The following is a description of a gene set: The attachment of one cell to another cell via adhesion molecules. species: Homo sapiens Human Gene Set: GOBP_CELL_CELL_ADHESION, and this is the list of marker genes: MIR141, CD58, BMI1, LGALS1, TLN2, JUP, FXYD5, SPI1, ESAM, ZFP36L1, NCAM2, SDK1, BOC, YES1, ELANE, METAP1 (methionyl aminopeptidase 1), FNDC3A, LRRC4, DAPL1, EPCAM, HES1, HBB, PCDHA6, CCL19, STXBP3, CEACAM6, CDH8, PODXL, SMARCD2, NFKBIZ, CELSR2, CBLB, CITED2, SPINT2, GLI2, VTCN1, ATP1B2, FUT7, ITCH, MIA3, CD84, IL2RA, NCK1 (NCBI Gene Id 4690), ANK3, CYFIP2, HLA-DPA1, CBFB, MIR221, GOLPH3, NFASC, CELA2A, ITGA2B, DLG5 (discs large MAGUK scaffold protein 5), IL12B, MMP24, PRKAA1, KIF26B (kinesin family member 26B), PTPN2, BMP7, PPP3CA, MYPN, BAIAP2, COL19A1, RAP2B, NLGN1, CADM2, EFNA5, CALCA (NCBI Gene Id 87044), PCDHGA1, CLSTN2, RGCC, HLA-DQA1, ITGB8, PCDHGC3, BHLHA15, PCDH8, DHPS, ITPKB, PTPRG, GP6, FGG, IGDCC3, ABL1, AKT1, FGFRL1, PCDHGB3, PLEKHA7, CDH7, NFKBID, DSCAML1, BSG, ANXA2, ARG2, ZBTB7B, IL1RAP, CYRIB, PTK7, PCDHGA9, MAP2K1, LAMA3, AMBRA1, TNFSF14 (TNF superfamily member 14), PCDHGC4, BTNL2, THY1, CD55, JAK3, ITGAV, HLA-DQB1, NTN1 (NCBI Gene Id 9423), TSPAN9, BAD, CCL5, PRKCQ, MIR125A, CD200, ZBTB16, SERPINF2, PCDH19, EPB41L5, PCDHA8 (protocadherin alpha 8), CLDN8, LRRC4C, CTNNA3, GCNT2, PRNP, TNXB, NLGN4Y, SELP (NCBI Gene Id 6403), CLDN2, SRPX2, TRIM29, NOD2, SCARF2, LRFN3, HLA-DRB5, LEF1, CX3CL1, PCDHB4, STAT5A, CDH1, SLC39A8, PVR, ATP2C1, PCDHB3, DSC3, JAK2, ITGA5, KRT18, CD2AP, CDON, MYL12A, MMRN1, CBLN1, NEXMIF, TUBB1, PCDHA9, CDH23, PCDHB12, EMB (embigin), SOCS5, PCDHB7, IL12A (interleukin 12A), ASCL2, PCDHA12, TNFRSF21, S100A9, TIGIT, FAT4, IL1A, CD6, FOXA2, FUT4, CXADR, ADGRG1, ITGA10, ADD2, CTNND1, SDC4, ARVCF, NTNG1, FUT9, CD80, FLOT1, NCK2, PCDHA13, TYRO3, LGALS8, SMARCD1, DLG2, LGALS3, CTSG, IGSF9, PIK3CG, SLITRK3, DUSP10, TNFRSF14, CCL21, TYK2, GNRH1, IGSF11, PTK2, CHST4, BCL2, SDK2, CD40LG, MTOR, KAT5, ADGRV1, DCC, CDH16, EGR3, NDFIP1, SOX12, CLDN18, AP3B1, HLA-DRB4 (NCBI Gene Id 3126), IGFBP2, BRD7, BMP4, TRAF6, AJUBA, AMIGO1, PCDHGA2, CXCL12, PSEN1, SOX4, RHOH, CDH20, SOCS1, TNFSF4, CARD11, IZUMO1, TMOD3 (tropomodulin 3), NKAP, SCARF1, IGDCC4, PCDHGA11, ELFN1, CDH18, STXBP1, CD5, ICAM4, ITGB4, WNT1, ITGB5, IL10, CDH12, CEACAM8, TGFB1, NPHP1, PCDH20, S100A8, GATA1, SCRIB, ST3GAL4, RARA, ROCK1, IL1RN, LIMS1, CLDN4, FOXP3, GPC4, CNTN5, PYCARD, ITGB6, CSK (C-terminal Src kinase), XG, CD70, ROBO2, SLAMF1, SLC6A4, HLA-DPB1 (major histocompatibility complex, class II, DP beta 1), UMOD (NCBI Gene Id 7369), CLDN3, KIT, SLITRK5, HSPB1, BVES, CADM1, THBS4, ACVR1, PCDHGA3, CLDN5, FGL2, PTPRM, PPIA, S100A11 (S100 calcium binding protein A11), MYL9, PLA2G2A, CD99, PIP5K1C (NCBI Gene Id 23396), IL7, ITGA1, PCDH10, CDSN, PCDHGA8, CCR7, PRKAR1A, RC3H2, PCDHA5, XCL1 (X-C motif chemokine ligand 1), ITGA7, CTNNB1, VMP1, RHOA, GRID2 (glutamate ionotropic receptor delta type subunit 2), LEP, PCDH11Y, CDH4, UFL1, ROBO4, MEGF11, PSG5, ALOX5, LYN, GPR65, CDH17, MIR21, MIR30B, SLITRK2, TNFRSF13C (NCBI Gene Id 115650), NEGR1 (neuronal growth regulator 1), FIBP, IL1RAPL1, MADCAM1, CORO1A, COMP, TSPAN32, PRDX2, PLPP3, VSIR, PCDH11X, PPARA, VSIG10L2 (NCBI Gene Id 338667), GTPBP4, KIRREL1, CADM3, STAT5B, ANXA1, ITGAL, IRF1, PTPRF (protein tyrosine phosphatase receptor type F), PTPRU, TNF, SASH3, ARID2, CTNNA2, RC3H1, ALOX12, NRXN2, PCDHGB1, ITGB1, PELI1, PTPRC, RAG1, TMIGD1, CASP3 (caspase 3), CLEC4G, GATA5, CDK5R1, MBP, KIFC3, OPA1, LILRB4, LAPTM5, ACTB, NTNG2, CSRP1, KIRREL3, EFNB3, SHH, CNTN2, ZMIZ1, EGFR, RDX, PKP4, CDH3, CLDN16, CD24, LGALS2, NECTIN2, DUSP3, CDHR4, CEBPB, CDH5, DLG4, ADAM19, AKNA (AT-hook transcription factor), MAP3K8, PLXNB2, HLX, C1QTNF1, LAG3, STXBP6, CRTAM, METTL3, ARG1, CDHR5, SMARCC1, ITGA9, IL36B, PCDHA2, RIC8A, B2M, OLR1, MYH9, TJP2, VAV1, FLOT2, PRKCA, PLAUR, CD44, FSTL3, TGFB2, SMARCE1, DSC2, COL13A1, GLDN, CLDN17, CLDN11, CCDC88B, NR5A2, PNP, NF2, EMILIN2, FGB, CD9, ETS1, VNN1, MSN, ZP3, ILDR2, VSIG4, SPARCL1, FUT3, CDHR2, EPHB3, CDH22, PCDHGB4, MYOT, TNFSF9 (TNF superfamily member 9), HLA-A, SOX9, SLC7A1 (NCBI Gene Id 6541), GPAM, WNT5A, LOXL3, TBX21, SART1, SLC7A11, TNFSF11, KLHL25, ZDHHC21, CCL28, WNT7B, PARVA, SFN, LRP6, UBASH3B, SOX2, BMP5, CBLL1, SLITRK1, IL1B, MAPK14, SIGLEC1 (sialic acid binding Ig like lectin 1), DSG2, RUNX1, NEO1, COL14A1, MIRLET7E, F2RL3, CDH15, PCDHGA5, CELSR1, MIR92A1, PCDHB6, SELPLG, CLDN19, TNFSF18, NOTCH1, PLXNB3, CTNNA1, PRICKLE1, DAB1, HSPH1, FOXF1, PCDHGA12, MPZ, IFNL1, RASAL3, SELE, LRFN4, KLHL22, SWAP70, RELA, COL8A2, CD4, PDGFRA, PCDH9, IL4I1, CLDN15, ICAM1, CYLD, HLA-DRB1, CRNN, SIRPA, NR4A3, PCDHB18P, MDK, TRO, CD28, ITGAD, ICOSLG, APOA1, PDPN (NCBI Gene Id 29912), ASTN1, JAG1, CLDN20, ADIPOQ, LRRC32 (NCBI Gene Id 2615), MIR31, MAP2K5, EFNB1, KITLG, PSG2, GATA3, PCDHGA10, MAD1L1, NECTIN1, VEGFA, IL4, ZP4, CAMSAP3, PDCD1LG2, DLG1, HMGB1, ZAP70, EFNB2 (ephrin B2), FADD, AMIGO3, PCDHB10, ANXA9, DSG1, CRB1, CCN3, MPZL2, TARM1, CCL25, STK10, CD81, CEACAM5, RAB10, PDLIM5, ELFN2, CD86, PLA2G2D, PCDHA10 (NCBI Gene Id 56139), ZBTB1, CDH10, FAT1, MUC21, PRTG, PRKCZ, PHF10, BTLA, BMP2, DOCK8 (NCBI Gene Id 81704), ENTPD1, PCDHGA4, MYO10, LRRC4B, PTPRD (protein tyrosine phosphatase receptor type D), ROBO3, NINJ1, PAG1 (NCBI Gene Id 55824), CYP1B1, IRAK1, SRF, FLRT3, MIR146A, HAVCR2, CX3CR1, EZR, ICAM2, PCDHAC1, FAT2, YWHAG, CLDN7, ARID1B, ASS1, LILRB2, CDH19, PLA2G2F, DSP, CD274, JAM3, DTX1, ITGA4, HLA-DQA2, PCDHA3, MAD2L2, PKP2, CDH11, SMARCA2, CCR2, TMEM131L, ZC3H12A, WNT10B, LGALS9B, RAC2 (NCBI Gene Id 5880), FERMT3, PCDHB9, GFUS, CD33, CR1, DPP4, CD160, BMP6, DCHS1, PCDHB13, ICOS, ITGAX, MFSD2B, VCL, CD69, ABCA12, IL7R, IL6ST, LIMS2, PECAM1 (NCBI Gene Id 5175), KIFAP3, IGF2, IFNA2, KLF4, PCDHB16, ITGA3, TJP1, IL1RL2, CDH6, SIRPG, TLN1, NINJ2, CNTN4, ACTG1, MIRLET7G, HLA-DRB3, ITGB3, PCDHGA7, IL23A, DSG4, SFTPD, NPTN, FBXO38, RAP1GAP (RAP1 GTPase activating protein), PKD1L1, CLDN10 (NCBI Gene Id 9071), DLG3, ITGA8, NOTCH4, PIK3CB (phosphatidylinositol-4,5-bisphosphate 3-kinase catalytic subunit beta), LRG1, EMILIN1, EXT1, NPNT, BLOC1S4, SPECC1L, CPLANE2, PLG, APOA4, F11R (NCBI Gene Id 50848), JAM2, LRFN5, MEGF10, PCDHGC5, L1CAM, SH2B3, CTLA4, CDH13, ITGAE, PCDHA1, PCDH18, SOCS6, SOX13, PTPRR, SPTA1, PCDHB1 (NCBI Gene Id 29930), PLA2G5, MDGA1, CLDN23, CAV1, PCDHA4, CD27, HTN1, LGALS9, ARID1A, NCKAP1L, TNR, TMX1, CXCL13, CNN3, NT5E, CLECL1P, CD200R1, GLI3, REG3A, FOXJ1, MALT1, RASGRP1, ADA, CD1D, IL21, NECTIN4, SRC (NCBI Gene Id 6714), IGF1, PLEKHG4B, PODXL2, CLDN12, PAK4, SERPINE2, IL2, SMAD7, SERPINB8, MYADM, ROPN1B, TTYH1, SELL, PCDHA11 (NCBI Gene Id 56138), PIK3R6, ADTRP (NCBI Gene Id 84830), CD47, MIP, CDC42EP1 (CDC42 effector protein 1), ADGRL3 (NCBI Gene Id 23284), CCN1, CNTN1, MINK1, MAPK7, ADAM8, BTN2A2, SHB, EPO, IGSF5 (immunoglobulin superfamily member 5), EPHA7, CD209, HMCN2, PRKCD, HFE, PPP1CA, RNASE10, WNT3A (NCBI Gene Id 89780), GPNMB, TNFSF13B, PERP, PDLIM1, PCDHB15, NLGN2, KLRK1 (NCBI Gene Id 22914), BCL10, TFRC, CD177, LCK, ZNF703, IL2RG, HTR2A, FGL1, B4GALNT2, RIPOR2 (RHO family interacting cell polarization regulator 2), CLSTN1, CLSTN3, PCDHGB6, EBI3, HLA-DOA, MARCHF7, CD74, RET, TNFAIP8L2, CDH9, NLRP3, IFNG (NCBI Gene Id 3458), NFAT5, HLA-E, PTPRT, IHH, TENM2, ILK, PCDHGA6, NPHP4, CLDN6, TESPA1, SLC4A2, PDCD1, VEZT, CDKN2A, CD164, CTNND2 (catenin delta 2), NLGN4X (NCBI Gene Id 64642), CERCAM, FCHO1, DSC1, FOXA1, ZC3H8, PCDHGB5, SEMA4D, JAK1, DCHS2, BCL6, ICAM5, IL4R, CADM4, LILRB1, PKD1, NPHS1, NRXN1, ACTL6B, RAG2, ITGAM, XBP1, NEXN, GCNT1, SHC1, PSG11, PKHD1, LGALS9C, PPM1F, SMARCC2, ALCAM, HLA-DQB2, PCDHB11, NECTIN3, HMCN1, JAML, CD300A, ASTN2, HAS2, SCGB1A1, ICAM3, PCK1, CSTA, LRRC7, SIRPB1, VSIG10, SYK, GLMN, BAIAP2L1, NRCAM, AFDN, PCDH12, PCDH15, PTPN23, AIF1, TJP3, IL6R, CNTN6, IL23R, CLIC1, FAT3, MAGI1, CD34, IL18, CLDN14, CD83, SELENOK, CD93, ZDHHC2, ITGB2, CRB2, SMARCB1, PIK3CD, TMIGD2, PCDHB8 (NCBI Gene Id 56128), PTPRS, KLRC4-KLRK1, ITGBL1, HLA-DMA, FGA (fibrinogen alpha chain), FOXO3, BRD2, TRPV4, NODAL, RIPK2, PEAR1, CLEC4M, PDIA3, IL6, PDPK1, TENM3, NRARP, AMIGO2, PDIA2, PCDHB5, PBRM1, YTHDF2, ACTN1, BRD4, UNC5D, TENM4, AGER, VCAM1 (vascular cell adhesion molecule 1), GNAS (NCBI Gene Id 82944), DNAJA3, DSCAM, LGALS7B, P2RY12, AP3D1, CD3E, PTPN22, RPS3, CDH26, CDHR1, PRKG1, LAX1, PALLD, NRXN3, CCL2, PCDHA7, CDHR3, DUSP22, HLA-G (major histocompatibility complex, class I, G), PCDH1, PKP1, PLEK, ADAM9, KIRREL2, TGFBR2, LPP, VPS33B, MIR27A, PCDHGB2, CLDN9, MIR222, FBLIM1, ABL2, TWSG1, PCDHGB7, PCDH7, CLDN22, LAMB1, IL20RB, FER, HLA-DRA, CD46, IL12RB1, HLA-DMB, IDO1, PKP3, CD37, PTPN11, CD276, CEACAM1, SKAP1, PTPN6, FYN, MAG, IFNB1, DSG3, DENND6A, ITGA11, CLDN1, ERBB2, SPN, HHLA2, PCDHAC2, ADORA2A, PIEZO1, IL15, SMARCD3, PCDHB14, DNAJB6, FLNA, HLA-DOB, ACTL6A, NLGN3, IGSF21, CDH24, SMARCA4, ZAN, CD2, TMEM47, CDH2, LRP5 (LDL receptor related protein 5), CELSR3, ROBO1, ADAMTS18 (ADAM metallopeptidase with thrombospondin type 1 motif 18), WNK1, HSPD1, CHST2, PAWR, PCDH17, MIR181C, RUNX3, WNT4, EP300, PCDHB2, ITGA6, TNIP1, ITGB7, ITGA2